Given this list of marker genes ADM, TACC3, RACGAP1, USP29, FOS, RRM2 (NCBI Gene Id 6241), DNAH5, here is a description of the gene set: from publication Johansson FK, Göransson H, Westermark B (PMID 15750623) Genes up-regulated in early vs late brain tumors induced by retroviral delivery of PDGFB. studied in species Mus musculus Retroviral tagging previously identified putative cancer-causing genes in a mouse brain tumor model where a recombinant Moloney murine leukemia virus encoding the platelet-derived growth factor B-chain (MMLV/PDGFB) was intracerebrally injected in newborn mice. In the present study, expression analysis using cDNA arrays revealed several similarities of virus-induced mouse gliomas with human brain tumors. Brain tumors with short latency contained on average 8.0 retroviral insertions and resembled human glioblastoma multiforme (GBM) whereas long-latency gliomas were of lower grade, similar to human oligodendroglioma (OD) and had 2.3 insertions per tumor. Several known and novel genes of tumor progression or cell markers were differentially expressed between OD- and GBM-like tumors. Array and quantitative real-time PCR analysis demonstrated elevated expression similar to Pdgfralpha of retrovirally tagged genes Abhd2, Ddr1, Fos, Ng2, Ppfibp1, Rad51b and Sulf2 in both glioma types compared to neonatal and adult normal brain. The retrovirally tagged genes Plekhb1, Prex1, Prkg2, Sox10 and 1200004M23Rik were upregulated in the tumors but had a different expression profile than Pdgfralpha whereas Rap1gap, Gli1, Neurl and Camk2b were downregulated in the tumors. The present study accentuates the proposed role of the retrovirally tagged genes in PDGF-driven gliomagenesis and indicates that insertional mutagenesis can promote glioma progression. Human Gene Set: JOHANSSON_BRAIN_CANCER_EARLY_VS_LATE_UP